The following is a description of a gene set: Human Gene Set: GOBP_PROSTANOID_BIOSYNTHETIC_PROCESS The chemical reactions and pathways resulting in the formation of prostanoids, any compound based on or derived from the prostanoate structure. species: Homo sapiens, and this is the list of marker genes: MIF (macrophage migration inhibitory factor), AKR1C3, CTHRC1, AVPR1A, PLA2G3 (phospholipase A2 group III), MIR132 (NCBI Gene Id 406921), TBXAS1, PNPLA8, AVP, PTGDS, EDN2, PRXL2B, HPGDS, PTGES2, IL1B, DAGLB, MIR766, FABP5, PTGES3, MIR204, PTGS1, PLAA, CD74 (CD74 molecule), PLA2G4A, SIRT1, PLA2G4F, CBR1, PIBF1, PTGES, PTGIS, EDN1, PLA2G10, PTGS2